The following is a description of a gene set: studied in species Homo sapiens Human Gene Set: chr12q21, and this is the list of marker genes: MIR1252, CEP290, SNORA70, LGR5, RNA5SP365, LINC02820, TSPAN8, LINC01619, ENSG00000258026, RNU6-1012P, LINC02424, ENSG00000297497, ENSG00000289218, DUSP6 (dual specificity phosphatase 6), RN7SKP172, CENPCP1, PHLDA1, ENSG00000289174, RNU6-977P, ZFC3H1, LINC02822, NTS, MGAT4C, RPL7P38, LINC02404, DCN, TBC1D15, MRS2P2, LINC02392, CCNG2P1 (NCBI Gene Id 100128681), MYF6, NAP1L1, PHLDA1-AS1, CCER1 (coiled-coil glutamate rich protein 1), RNU6-1271P, TPH2, RPL23AP68, LINC00615, BBS10, PRXL2AP1, NAV3, KRR1, LNCOG, LINC02464, SNRPGP20, PAWR, ENSG00000257787, OSBPL8, TSPAN19, RLIG1, RPL21P98, RNU1-117P, RNU7-106P (RNA, U7 small nuclear 106 pseudogene), POC1B-GALNT4, LINC02882, KITLG, GLIPR1L2, LINC01490, LINC02823, LIN7A, ENSG00000201809, LINC02394, METTL25, VENTXP3, ENSG00000289309, RPL7P43, BRWD1P2, BTG1-DT, TMTC2, RN7SL734P, GLIPR1, PPFIA2, MRPL2P1, NOP56P3, RPL31P48, CAPS2, KERA, THAP2, LINC02258, PHLDA1-DT, LINC02426, EPYC, RPL6P25, TMTC3, LUM, BTG1, AKIRIN1P1 (NCBI Gene Id 100418731), ATP2B1, TRHDE-AS1, RPL7AP9, ZDHHC17, GLIPR1L1, MIR617, POC1B, DENRP2, CCDC59, LINC02458, SLC6A15, RNU6-148P, RN7SKP261, RNA5SP364, CHCHD3P2, CYCSP30, ACSS3, CAPS2-AS1, RAB21, RNU7-120P, GALNT4, ENSG00000212461, PPP1R12A, RPL10P13, LINC02444, C12orf50, SYT1, ATP2B1-AS1, ENSG00000306515 (NCBI Gene Id 124902965), PPFIA2-AS1, OTOGL, TRHDE, TMEM19, LINC02445, H3P35, RPL21P106, MIR4699, PPP1R12A-AS2, PPP1R12A-AS1, GLIPR1-AS1, ALX1, RASSF9, MKRN9P, MIR618, RNA5SP363, KCNC2, YWHAQP7, E2F7, POC1B-AS1, RPS4XP15, ATXN7L3B, LRRIQ1, CSRP2, PTPRQ, MYF5, MRPS6P4